Given this list of marker genes FADS1, FADS2, CYP4F3, ALOX5, ACSL1, here is a description of the gene set: Human Gene Set: WP_SEBALEIC_ACID_FORMATION_AND_METABOLISM Sebaleic acid formation and metabolism studied in species Homo sapiens